The following is a description of a gene set: part of: SLC transporter disorders Reactome Pathway: Defective CP causes aceruloplasminemia (ACERULOP) species: Homo sapiens Ceruloplasmin (CP), synthesised in the liver and secreted into plasma, is a copper-binding (6-7 atoms per molecule) glycoprotein involved in iron trafficking in vertebrates. CP is essential for SLC40A1 (ferroportin) stability at the cell surface, the protein that mediates iron efflux from cells. CP also possesses ferroxidase activity, which oxidises ferrous iron (Fe2+) to ferric iron (Fe3+) following its transfer out of the cell. Fe3+ can then be loaded on to extracellular transferrin which transports it around the body to sites where it is required. Iron is vital for many metabolic processes such as electron transport and the transport and storage of oxygen.<br><br>Defects in CP (or indeed SLC40A1) can lead to the phenotype of iron overload as seen in the disorder aceruloplasminemia (ACERULOP; MIM:604290). It is a rare autosomal recessive disorder of iron metabolism characterised by iron accumulation mainly in the brain, but also in liver, pancreas and retina. Patients develop retinal degeneration, diabetes mellitus and neurological disturbance. ACERULOP belongs to a group of disorders known as NBIA (neurodegeneration with brain iron accumulation), distinguishing it from hereditary hemochromatosis (serum iron is high but the brain is usually not affected) and from disorders of copper metabolism such as Menkes and Wilson disease., and this is the list of marker genes: SLC40A1, CP